The following is a description of a gene set: An eyebrow that extends laterally beyond the orbital rim rather than turning gently downward at that location. species: Homo sapiens Laterally extended eyebrow Human Gene Set: HP_LATERALLY_EXTENDED_EYEBROW, and this is the list of marker genes: NUP188, MAB21L1, SMC3, MYCN, MEIS2